Given this list of marker genes STRIT1, MRLN, ATP2A2, PLN, ZMPSTE24, ATP2A1, SLN, here is a description of the gene set: species: Homo sapiens The directed movement of calcium ions into a sarcoplasmic reticulum. Human Gene Set: GOBP_CALCIUM_ION_IMPORT_INTO_SARCOPLASMIC_RETICULUM